Given this list of marker genes CADPS, SOX4, FAM161A, NRL, NTM, CAMK2B, NDRG1, FSTL5, TUBB4B, FABP7, MRLN, NEUROD1, CNGB1, AMER2, SRRM4, OTX2, NR2E3 (NCBI Gene Id 51736), ANKRD33B, SNAP25, PCBP4, NEUROD4, RCVRN, AHI1, KCNV2, RP1, PRPH2, ROM1, PLEKHB1, SYT1, NNAT, AIPL1, PTPRZ1, PTPN13, SLC38A5, CKB, GNB3, TERT, SLC1A7, TMEM244, MAK, H4C3, PDC, CRX, TPI1, FOS, AKAP9, GADD45G, DUSP1, CDHR1, UNC119, RAX2, GRM6, MIR124-1HG, AANAT, RBP3, IMPG2, VAMP2, GNAT1, BAZ2B, ATP1B2, MPP4, RIMS2, GNGT2, CCDC181, H3-3B, BTBD8, PRDM1, EPB41L2 (NCBI Gene Id 2037), PROM1, SLC17A7, TULP1, UBXN4, here is a description of the gene set: Human Gene Set: HU_FETAL_RETINA_PHOTORECEPTOR from publication Hu Y, Wang X, Hu B, Mao Y, Chen Y, Yan L, Yong J, Dong J, Wei Y, Wang W, Wen L, Qiao J, Tang F (PMID 31269016) species: Homo sapiens Rod Photoreceptor Cells